The following is a description of a gene set: Genes down-regulated during transition from L1 (non-tumor, infected with HCV) to G1 (well differentiated tumor, infected with HCV) in the development of hepatocellular carcinoma. from publication Iizuka N, Oka M, Yamada-Okabe H, Mori N, Tamesa T, Okada T, Takemoto N, Sakamoto K, Hamada K, Ishitsuka H, Miyamoto T, Uchimura S, Hamamoto Y (PMID 15710396) species: Homo sapiens Human Gene Set: IIZUKA_LIVER_CANCER_PROGRESSION_L1_G1_DN Using high-density oligonucleotide array, we comprehensively analyzed expression levels of genes in 50 hepatocellular carcinoma (HCC) samples with positive hepatitis C virus (HCV) serology (well (G1), moderately (G2), and poorly (G3) differentiated tumors) and 11 non-tumorous livers (L1 and L0) with and without HCV infection. We searched for discriminatory genes of transition (L0 vs. L1, L1 vs. G1, G1 vs. G2, G2 vs. G3) with a supervised learning method, and then arranged the samples by self-organizing map (SOM) with the discriminatory gene sets. The SOM arranged the five clusters on a unique sigmoidal curve in the order L0, L1, G1, G2, and G3. The sample arrangement reproduced development-related features of HCC such as p53 abnormality. Strikingly, G2 tumors without venous invasion were located closer to the G1 cluster, and most G2 tumors with venous invasion were located closer to the G3 cluster (P=0.001 by Fisher's exact test). Our present profiling data will serve as a framework to understand the relation between the development and dedifferentiation of HCC., and this is the list of marker genes: ATP6V1E1, UFD1, CAMKK2, TBCE (NCBI Gene Id 6905), SNRPB, ILF2, DRAP1, RNF103, CADM1, GOLGA3